Given this list of marker genes RAB11B, EXT2, PLP1, MPZ, VCP, BCORL1, GNB2, TBC1D23, MAN1B1, RFX7, CUL4B, TOP3A, GALC, COL9A2, SPTAN1, TRPV4, PRX, MED12, KMT2A (lysine methyltransferase 2A), CDK10, ADGRG1, HTT, TWNK, KCND3, DEAF1, TMEM222, RNU4-2, TBP, TRIM2, PIEZO2, COPB2, SPTBN2, GBA2, HACE1, ATP10A, MTTP, DYRK1A, SPTBN1, PEX5, PACS2, SIM1, SATB2, GPT2, POLG, PRDM13, SMS, EBF3, DNAJC12, CCDC88C, CAMTA1 (NCBI Gene Id 23261), GTF2E2, PURA, SNRPN, VLDLR, SGCG, DLAT, MAP1B, CLTC (NCBI Gene Id 9511), GTPBP2, TPP1, RNU12 (RNA, U12 small nuclear), BICD2, ATCAY, CARS1 (NCBI Gene Id 833), ACTL6B, XRCC4, SLC9A7, TKFC, MECP2, RNF113A, YWHAG, CHD3, PPP1R15B, CERT1, NRXN1, SRCAP, WDR26, NSUN2, RAI1, WDR81, SGCB (NCBI Gene Id 6443), RNASEH1 (ribonuclease H1), FLVCR1, FNIP1, TMEM106B, SHANK3, TRAPPC6B (NCBI Gene Id 122553), NKX2-1, TRMT10A, AP5Z1, NAT8L, TINF2, NBEA, PPM1D, UBE3A, RBM10, SLC6A8, TPR, AHDC1, OCA2, PIGL, THRA (thyroid hormone receptor alpha), PMP22, UROC1, COQ2, ZEB2, MAB21L1, BCL11A, EGR2, ZSWIM6, CAD, CWF19L1, SNX14, WASF1, NDUFAF2, ITPR1, DDX3X, MPV17, GBA1, RLIM, here is a description of the gene set: studied in species Homo sapiens An abnormal gait pattern in which persons stand and walk with their feet spaced widely apart. This is often a component of cerebellar ataxia. Broad-based gait Human Gene Set: HP_BROAD_BASED_GAIT